Given this list of marker genes Adss1, Zfp697, Crat, Mia3, Gad1, Stk38, Slc35d2 (solute carrier family 35, member D2), Adora2a, Cspp1, Jade3, Nfat5 (nuclear factor of activated T cells 5), Krt87, Tcaf1, Mbnl3, Nfxl1, Ror1, Zfp992, Btaf1, Sparcl1, Wrnip1, Pkdcc, Zfp386, Add3, Stc2, Mboat1, Tcerg1, Lmtk2, Sema6a, Cep43 (NCBI Gene Id 75296), Nav2, Cnih4, Rala, Cbfa2t2, Rsbn1l, Lmbr1l (limb region 1 like), Apba1, Snap91, Tmem161b, Hic2, Mcat, Dpp10, Dll1, Csnk1g1, Entpd6, Phlpp2, Zcchc14 (NCBI Gene Id 142682), Ndst2, Rbm27, Il1r1, Pgm3, Mex3a, Ceacam19, Gucd1, Capns2, Zbtb37, Rnf222, Skida1, Kif2a, Efs, Ugt2b37, Tefm, Med13, Sphkap, Cd28, Prdm1, Fasl, Odf2l, Fyb2, Usp2, Ube2d2a, Kcnj8, Agps, Hira, Tnks, Usp37, Lsm14b, Klhl17 (kelch-like 17), Eml6 (NCBI Gene Id 73111), Abraxas2, Clcn3, Nlk, Ppp1r16b, Eda2r, Srpk2, Ppl, Reep2, Gm14137, Osbpl8, Zfp654, Tlnrd1, Git1, Bzw1, Rtp3, Tada2b, Crip3, Tmprss11b, Pigv, Ago4, 9930012K11Rik, Il18r1, Atad2b, Pkp2, here is a description of the gene set: Genes predicted to be targets of miRBase v22 microRNA mmu_miR_3106_5p in miRDB v6.0 with MirTarget v4 prediction scores > 80 (high confidence targets). studied in species Mus musculus Mouse Gene Set: MIR_3106_5P from publication Chen Y, Wang X (PMID 31504780)